The following is a description of a gene set: species: Homo sapiens Human Gene Set: MIR558 Genes predicted to be targets of miRBase v22 microRNA hsa-miR-558 in miRDB v6.0 with MirTarget v4 prediction scores > 80 (high confidence targets). from publication Chen Y, Wang X (PMID 31504780), and this is the list of marker genes: ECT2, CENPV, PBX2, RCOR1, TMEM140, BCL2L14, CAPRIN1, NALF2, OLFML2A, EDARADD, TPM1, MBNL3, RGS8, CNOT6L, APOBEC4, ULK1, CUL3, ITGBL1, AQP4, ZNF217, SCGB2B2, ELFN2, ZZZ3, TJAP1, SEC11A, ANKS1A, CARD8, MTMR2, LRRC73, DTNA, RANBP6, LRRC1 (leucine rich repeat containing 1), CD84, CADM1, PVR, LRPAP1, NIPA1, NECAP1, RBM46, HMGB2, CLIP2, DIS3L2, ELF2, STK26, EDC3, TMCO4, SEPTIN8, DPYSL5, CGREF1, STK39, MXI1, NPR2, KAT2A, KCNA1, NIPA2, BTF3, WWC3, LAMP1, PDS5B, ZFAND5, FBN2, SLC24A1, PLD1, TRIP12, COPS2, LPP, TARP, BCL2L11, PDE7A, PDE12, NAA30, RMND5A, GBP4, NUDT2 (nudix hydrolase 2), OSR2, FNBP4, APCS, FBXO41, SLC35D1, DIDO1, SENP7, SLC8A1, ZFP14, TBC1D14, HOXA4, THSD4 (NCBI Gene Id 79875), KAT6A, RAPH1, WDFY1, DPYSL2, HS6ST3, PTBP3, RNF8, FLNC, JAG1, RNF19A, KALRN, DESI2, WIPF3, DPF2, RBSN, CDKN2AIP, SFXN1, LPGAT1, HECTD1, PTPN11, BTBD9, GIPC3, HOXC8, HOXA1, MRPL12, ABCC5, LEFTY2 (NCBI Gene Id 96286), ZCCHC3